The following is a description of a gene set: studied in species Homo sapiens Camptodactyly is a painless flexion contracture of the proximal interphalangeal (PIP) joint that is usually gradually progressive. This term refers to camptodactyly of one or more toes. Camptodactyly of toe Human Gene Set: HP_CAMPTODACTYLY_OF_TOE, and this is the list of marker genes: PRG4, GLI3, MYL11, PHF6, IPO8, BCOR, FHL1, DSP, MMP2, PPP2R5D, FBN2, SCARF2 (NCBI Gene Id 91179), FLNA, JUP, FGFR3, CHRNG, PIEZO2